The following is a description of a gene set: Mouse Gene Set: GOCC_UNCONVENTIONAL_MYOSIN_COMPLEX studied in species Mus musculus A portmanteau term for myosins other than myosin II., and this is the list of marker genes: Myo18b, Myl6b, Mlph, Myo7a, Myo5a, Myl6, Dynll2